The following is a description of a gene set: species: Homo sapiens from publication Riggi N, Suvà ML, Suvà D, Cironi L, Provero P, Tercier S, Joseph JM, Stehle JC, Baumer K, Kindler V, Stamenkovic I (PMID 18381423) Genes up-regulated in mesenchymal stem cells (MSC) engineered to express EWS-FLI1 fusion protein. Human Gene Set: RIGGI_EWING_SARCOMA_PROGENITOR_UP Ewing's sarcoma family tumors (ESFT) express the EWS-FLI-1 fusion gene generated by the chromosomal translocation t(11;22)(q24;q12). Expression of the EWS-FLI-1 fusion protein in a permissive cellular environment is believed to play a key role in ESFT pathogenesis. However, EWS-FLI-1 induces growth arrest or apoptosis in differentiated primary cells, and the identity of permissive primary human cells that can support its expression and function has until now remained elusive. Here we show that expression of EWS-FLI-1 in human mesenchymal stem cells (hMSC) is not only stably maintained without inhibiting proliferation but also induces a gene expression profile bearing striking similarity to that of ESFT, including genes that are among the highest ESFT discriminators. Expression of EWS-FLI-1 in hMSCs may recapitulate the initial steps of Ewing's sarcoma development, allowing identification of genes that play an important role early in its pathogenesis. Among relevant candidate transcripts induced by EWS-FLI-1 in hMSCs, we found the polycomb group gene EZH2, which we show to play a critical role in Ewing's sarcoma growth. These observations are consistent with our recent findings using mouse mesenchymal progenitor cells and provide compelling evidence that hMSCs are candidate cells of origin of ESFT., and this is the list of marker genes: SERPINB9, NPTX2, CYP26B1, ISYNA1, GRP, GRIA2, ABCA5, HSD17B2, CLSTN2, SEMA6D, SMARCC1, ALDH5A1, CARD16, ARHGDIB, TOX2, ZSWIM6, NKX2-2, SHISA9 (shisa family member 9), MEIS1, STING1, MRAP2, TNNT1, FRZB, GPR37, EDNRA, SULT1A2, JPH1, FLRT2, HDAC9, FRK, RBM24, ICAM1, LINC00839, CDS1, GUSBP14, CLCA1, TGFA, LPL, WDFY2, FABP4, TRDN, ACACB, ICAM2, KRT17, TSPAN13, WT1 (WT1 transcription factor), KASH5, SAMD5, FADS3, SH2B3, IL1RAP, HBEGF, CTSH, ATG16L1, APELA, L3MBTL3, SIGLEC15, CORIN, BTG2, H2AC6, GATA2, MMP9, PEG3, CSPG5, LRRC4C, STAR (steroidogenic acute regulatory protein), STMN4, LIN7B (lin-7 homolog B, crumbs cell polarity complex component), RNF228, NFATC3 (nuclear factor of activated T cells 3), NR0B1, CD274, PKP1, HSPB2, PGF (NCBI Gene Id 5228), SOX2, JAG2, IGFBP5, STMN3, GNA14, SLCO5A1, SLC35F2, SLFN12, AQP3, LINC02762, RIMKLB, NTRK1, ZCCHC12, SLAIN1, ABHD6, PTGDS (NCBI Gene Id 5730), KALRN, NUDT11, PODXL, STEAP2, A2M, ASAP1 (NCBI Gene Id 56237), PADI2, MAPT, PDLIM1, TMEM178B, SH3TC1, TNC, CD14, PTGER3 (NCBI Gene Id 5733), STK32B, CDC37L1, H2BC12L, SLC39A8, CDH4, CD36, PLCG2, KIT, LYPD1, GLCE, ZNF703, STEAP1, LMO2, DAB1, HSPB8, SHISA3, SEL1L3, MMP8, JCAD, CDK14, EPHA4, BHLHE41, MMP13, PALM2AKAP2, RGS5, C3AR1, SEC14L1, FAT4, OPN3, ENPEP, LRATD2, PTPN22 (NCBI Gene Id 5779), PCDH7, ADARB1, TCF12, EVA1C, CLIC3, LGALS8, NOS1, CACHD1, BCL11B, SLC26A2, SCNN1G, CALCA, NR2F1, ADRB3, TCF4, AP4B1, PRXL2A, MAPRE2, NRK, CST6 (cystatin E/M), MAP7D2, RARRES2, POC1B, CEACAM1, STAT4, TRIM35, GLG1, TRHDE, IFITM1, ARHGEF6, PREX1 (NCBI Gene Id 57580), NPY1R, CRIP2 (NCBI Gene Id 8112), EPHA3, MALAT1, RNASET2, S1PR3, DUSP6, PCSK2, SLC5A6, GPD2, TBXA2R, TMEM132B, PLA2G4C, PIK3R1, FOS, FAM43B, PCDH17, LMO3, P2RX7, FLRT3, ITGB2, ATP1A1, HLA-E, FBLIM1, RAMP1, MARCKSL1, PTGS2, KMO, HS6ST1, GUSBP3, GP1BB, PRSS35, PRKCB, TMEM37, CITED2, AKR1B10, ZNF91, PLXDC2, OLFM3, ODF2L, KIAA1549L, SLC17A7, PLA1A, DLG2 (NCBI Gene Id 283225), RNF141, SOX6, JAK1, MYOM2, JARID2, ITGA4, LBH, DCLRE1B, NRCAM, RAPH1, CASP1, PNOC, MYO10 (myosin X), IGFBP2, TMEFF2, CYTL1, TRMT9B, PPP1R14A (NCBI Gene Id 94274), MSX1, CTTNBP2, YPEL5, EPHB1 (NCBI Gene Id 2047), NLGN4X, SH3GL3, UPP1, GDF15, PCDH9, RRAGD, UTS2, COL4A4, IFI44, COL21A1, ADAMTS3, PARM1, CEP112, EFHD2, GPX3, CRYGS, NTNG1, DMD, UHMK1, SORD, PRELP, H2BC5, ITGAM, MCUR1, DGKD, NELL2, ZNF711, TALAM1, NT5DC1, WFDC1 (NCBI Gene Id 58189), CSRNP3, RSPH3, GRK5, LSM8, G0S2, IKZF2, PTGER4, FZD8, ANKS1A, JAK3, HIVEP3, CCND2, FAT3 (FAT atypical cadherin 3), GFRA2, LRRN3, BST2, MFAP4, KRTAP4-9, CCDC171, ST6GAL1, GDF7, REEP1, CLDN1, LINGO1, RGS18, EZH2, LINC01503, STEAP3, MAFB, GALNT3 (NCBI Gene Id 2591), AKAP7, TCF7L1, ENPP1 (ectonucleotide pyrophosphatase/phosphodiesterase 1), C1orf226, LAPTM5, CES1, RUBCNL, PGLYRP2, IL13RA1, TM4SF20, TDO2 (NCBI Gene Id 6999), ZNF704, COL11A1, GIMAP2, C5, OLFML3, COLGALT2, TRIB2, KDSR, SLC15A2, LANCL3, FNBP1, CALCB, CDH11, KLHL13, MARCHF1, LRATD1, LDB2, PDGFA, IGSF3, MMP1, ITGB2-AS1, ZDHHC21, GPR17, GCH1, TM6SF1, ANKRD1, ZC3H13, EXOSC4, DUSP7, PRR5L, F2R, ADGRG2, MROH2A, LAMB3, LMO4, RELN, SV2B, UBE3D, PTPN13, CYP4F22, UGT3A1, FZD4, KCNK3, CYP2R1, H4C8, PAG1, TBX3, ALG6, PCGF5, TSPAN11, ITM2A, GRIK2, TRPM4, DKK2, ENTPD3, NGFR, GPR137B, FMOD, FZD1, IGDCC4, H2BC7, SLIT2, RGS2, KIAA1217, GYG2, DUSP5, SSBP4, C15orf48, FCGRT, RCOR1, CHCHD10, EFHD1, CADPS2, CLCA2, ID4, HES1, ATP11B, SLC24A3, FAM107B, SYNPR, PAQR5, CYYR1, NR3C2, LRFN5, DAPK1 (death associated protein kinase 1), PRSS23-AS1, FREM1, H2BC6, BRINP1, TNFSF15, KBTBD8, BAMBI, EBF2, FARP1, ADGRE2, TGFB1, PBX1, ECRG4 (ECRG4 augurin precursor), H2BC4, ERFE, SCIN, PGM2L1, MAP3K5, MCAM, HVCN1, CRIP1, JAG1, LEF1, GIMAP8, KCNE3, CREM, FAM43A, KCNE4, ALK, PSTPIP1, BHLHE22, MAMDC2, SLFN11, LRP8, ID2, ZBTB16, SPP1, IGF1, PPFIA3, SPATA13, GABRQ, ALDH7A1, OPCML, NPR3, DNAJC12, FGF18, PVR, HMCN1, CRYAB